Given this list of marker genes NCSTN, RILPL1, OSTM1, PHIP, IL23R, BACH2, AASS, BLNK, H4C3, CTRC, ANLN (NCBI Gene Id 54443), FOXP3, FASLG, PGM2L1, DAAM2, CYP7B1, PTEN, SMARCA2, ATM, CRB2 (crumbs cell polarity complex component 2), EMP2, EPB42, CREBBP, PLG, CRLF1, SKIC3, TREX1, IFT27, HAVCR2, SERPINH1, FRG1, MEIS2, LPL, NPHS2, COL3A1, TCF3, MT-CO3, CORO1A, HR, TNFRSF1B, DNAJB13, DNAH1, LTBP1, TNFSF4, CDC42BPB, TGFB2, ARPC1B, KPTN, DNAJC21, C2orf69, SIAH1, ORC6, SLC35C1, FGFR3, SEMA4D, IDUA, ESAM, C3, PML, SLC12A3, NODAL, WRAP53, SCAPER, RNU12, IL10RA, TBCD, FMR1 (NCBI Gene Id 5421), TBL2 (NCBI Gene Id 27203), MEGF10, BSCL2, HDAC8, TAF6, OCRL, TRAPPC11, PSPH, ANK1, ERCC2, GJB6, GTF2IRD2, NME8, TBC1D8B, NDUFS3, ACTA1, FGF3, CYBB, ARID1A, TNPO3 (NCBI Gene Id 404679), APOE, TLK2, TBC1D2B, AKR1D1, PRG4, ARHGAP24, ASXL1, GJA1, GNPTAB, BBS9 (Bardet-Biedl syndrome 9), CARD14 (caspase recruitment domain family member 14), POU2AF1, TNFRSF9, CD2AP, ABCB1, MT-TF, G6PC1, PIK3CD (NCBI Gene Id 5293), ERCC1, PCCB, MT-ND1, APC2 (APC regulator of WNT signaling pathway 2), SOX11, UFD1, IFT140, NPHP1, UQCRH, GJB2, SREBF1, KDM1A, MEG3, STAT1, SCN9A, ERBB2, ETS1, FOXD3, NLRP1, NHLRC1, AMACR, XPNPEP3, IQSEC2, SH3PXD2B, SLC19A1, POLR3A, PIEZO1, CSPP1 (NCBI Gene Id 79848, centrosome and spindle pole associated protein 1), CACNA1G, RANBP2, HACD1, COL4A5, WDR1, INF2, STUB1, ST14, IL1RN, CYP7A1, MYO1E, LTBP3, EYA4, CST6, COPA, SEMA3C, MTHFD1, USP8, MLX, CBL, LSS, SCNN1A, NCF1, RARA, ZBTB7A, MKS1, TGFBR1, BLOC1S6, DLG1, KCNJ6, IKBKB, RAD21, IGKC (NCBI Gene Id 3514), PLEKHM1, DIP2B, EFEMP2, WDR19, NUP160, CIITA, CTSB, PRMT7, MSN, DNAAF5, NCF2, IL18BP, KIRREL1, TNFRSF1A (TNF receptor superfamily member 1A), TRIM32, PLEC, COG6, RSPH4A, AGR2, CD27 (CD27 molecule), COBLL1, ACTN4, CCDC39, HPS1 (NCBI Gene Id 3257), CIB1, MRTFA, SLC39A7, LEP, TRAPPC2, MMUT, IL6, MT-TS2, ATN1, RFXAP, UBA1, DGKE, NLRP3, EFL1, NEK9, CASR, PRKACA, ACTG2, IGBP1, SLCO2A1, ANO5, STXBP1, CDK10, MAP3K7, BPTF, RECQL, MT-ND6, TLR7, ZEB2, TGDS, STAT6, DNAAF11, CCDC40, SLF2, TGM5, POMP, CPLX1, C1QC, CAV1, PNP, THRB, PAX1, NOTCH2NLC, LRBA, DAW1, SDHA, CD79B, CARMIL2, ZMYM3, PTPRC (protein tyrosine phosphatase receptor type C), FMO3, ELOVL4, SMARCA4, RUNX2 (NCBI Gene Id 860), RAG2, CTLA4, PRKCD, ARHGDIA, GANAB, TNFSF12, IGHG2, ADAR, SRCAP, RBM8A, ANKH, TGFB1, CDKN1B, PIK3R1, IRF5, CEACAM3, KCNN4, KMT2D, STXBP2, TNFRSF11B, KRT10, REV3L, RNF2, COL2A1, DNASE2, JMJD1C, EDARADD, SPTA1, BTD, GTF2IRD1 (NCBI Gene Id 9569), EPHB4, EP300, KMT5B, CLEC7A, CEBPE, KDF1, CFAP74, XIAP, IL2RG, ITK, SPEF2, FBXW7, MME, TOM1, TP53, FECH, DUX4L1, RIT1, RFX7 (NCBI Gene Id 64864), CD28 (NCBI Gene Id 940), IL10RB, PTCD3, ELN, IL12B, GFI1, ARID2, MIA3, MMACHC, AARS1, MALT1, SMG9, JAK2, ZNFX1, CYP4F22, SF3B1, FOXP1, PI4KA, EPCAM, ITGA7, H3-3B, RMRP, DNAH5, HPGD, MAN2B1, RNF113A, ADAMTSL2, MAGI2, NFKB2, HNRNPA2B1, PMM2, DRC1, BCOR, PGM3, TLR8, KANSL1, PLCH1, MBTPS2, NIPBL, OTULIN, CDC73, COX4I2, AXIN1, SLC30A2, TTC12, TNRC6B, DUX4, DOCK8, ERCC3, LAGE3, STX11, KCTD1 (potassium channel tetramerization domain containing 1), IRF1 (NCBI Gene Id 96501), PSTPIP1, XDH, AP1S3, STAT3, SLC2A10, FKBP6, CFTR, LZTFL1, NAE1, MAP2K1, ERCC8, NME5, GCGR, NAA10, STAT5B, PDCD1, SGCG, FLNA, EXTL3, PDGFRL, TNFAIP3, FGF8, NPHS1, CDSN, RNU7-1, ACP5 (NCBI Gene Id 54), PIGH, DLX4, KIF12, DSG1, KANK2, ZNF750, CD81, IL6R, FOXC2, TBL1XR1, STIL, AR, NGF, BCS1L, MEFV, PRSS1, LPIN2, ITGB4, MYH9, ZNF341, AGA, CEACAM6, KRT5, SHOC2, TK2, EPG5, C1S, SFTPB, ALDH18A1, BICC1, CBS, CITED2, CEP19, IFT172, TMC8, ATL3, IDH1, STIM1, DNAAF1, LMNA, CD3D, PERCC1, IGSF3, LTBP4, ANKRD55, SELENON, AK2, DEF6, NAXD, RBCK1, EDAR, BBS12, SLC27A4, MYD88, CR2, ELANE (NCBI Gene Id 6417), LIMK1, CFB, NEK10, KRT14, BAZ1B, AEBP1 (AE binding protein 1), CSTA, CD4, TRPM4, SLC25A12, SMG8, TNFSF15, TBX4, STK36, ARHGEF38, PIGY, GPIHBP1, PTPN6, SCLT1, IGF2R (insulin like growth factor 2 receptor), HBA1, AP3B1, PSMB4, MET, CFAP300, TRIM44, NRTN, GLRB, A2ML1, WDPCP, COMT, KIAA0586, ATP8B1, GAS1, CDCA7, SMARCAL1, RNU4ATAC, SDR9C7, ABCD1, CTC1, GATA1, NUP205, PLCE1, IL12RB1, SMARCB1, CEP290, FGF10, MAB21L1, CERS3, STAT2, SOX18, SLC6A14, GK, KLK11, MTTP, PRORP, PRDM12, FCGR3B, TNIP1, HGD, IL21R, PANK2, EDA, ERCC4, KAT6A, JAGN1, GTF2I, NR1H4, AP1B1, DCLRE1B, RRAS2, RNASEH2B, UBB, IL1R1, NSMCE2, MECP2, METTL27, COL4A4, LMF1, PAPSS2, GJB4, GNB2, GLRA2, DDB2, GATA2, SCNN1B, NUP133, FXN, LONP1, REL, MGP, B4GALT1, SPTBN1, TBK1, NUP93, MNX1, HFE (NCBI Gene Id 3077), TFE3, IFNGR1, PAH, NBN, PRSS2, INSR, FCHO1, C1QB, PTPN22, RSPH3, DNASE1L3, ADA, GIPC1, ACADVL, HLA-DPB1, ALMS1 (NCBI Gene Id 7840), ABCB4, SPTLC2, SLC11A1, POLH, LBR, USB1, CAMK2B, HMOX1, TBX1, TAPBP, BBS4, RFC2, FNIP1, NOS1, RNF125, IL2RB, TPP2, AKT1, COQ8B, GLRA1, KDSR, DISP1, NOD2, GSTM3, MED25, SMC1A, CD151, RFXANK, ERCC6, MTM1, SETD2, IL7R, COL7A1, MED12, CARD10, SH2D1A, DNASE1, BBS5, SMARCD1, PSMB8, AHDC1, RAG1, TG, ABCA12, MAX, IGLL1, MEN1, RETREG1, ARID1B, BTNL2, SFTPC, IFT74, PLXND1, HLA-B, BMP4, MKKS, PHGDH, CCNO, NOTCH2, HYAL1, MBL2, BLK, CFAP410, BTK, RNF168, LRRC8A (NCBI Gene Id 56262), ZFAT, POFUT1, GSN, LMX1B, FGFR1, C1R, AUTS2, DNAAF4 (dynein axonemal assembly factor 4), DNAI2, TPR, MARS2, ABCA3, FCN3, GMPPA, CLDN1, RAB7A, NOP10 (NCBI Gene Id 55505), NPM1, IL17RC, ARSB, APOC2, CASP10, BLM, ALG5, MMP1, NR3C1, MID1, COL11A2, CD19, LPIN1, FGFR2, NSMCE3, TP73, GLIS3, CPA1, FOXH1, RAP1B, MRAP, XPC, SOCS1, PDHA1, DNAH7, SLC25A13 (solute carrier family 25 member 13), FAS, TMCO1, LIG4, LYN, CD247, TBX20, SPAG1, CHD6, TRAF6, HLA-DQB1, TRPC6, MAF, BRD4, JAK1, MPDU1, DDR2 (discoidin domain receptor tyrosine kinase 2), GNAQ, OPLAH, DLL1, COL4A3, TGM1, HSD3B7, VPS33A, MCIDAS, MTAP, TAP2, H4C5, BBS2, LRIF1, CFHR5, ODAD4, KDM6A, CARD8, MST1, GPR101, LYST, PIGG, ALG9, TTC8, ACTC1, CIDEC, GGT1, WDR26, GORAB, CFAP45, ARMC5, DNAH9, DNAH11, DNMT1, SLC9A3, KNSTRN, BBS10, CTNNB1, ROR2, RIC1, POLE, IRAK1, TAF4, CDC45, C4A, B3GALT6, GUCY2C, SLC29A3, PTCH1, SIK3, NFKB1, KIF11, IRF6, GUSB, RPGR, PSENEN, RPL11, BUD23, ERF (ETS2 repressor factor), AAAS (aladin WD repeat nucleoporin), LHCGR, SLC39A4, SIX3, SP110, RREB1, ATRX, POGZ, P4HA2, CLIP2, MYL2, IRF4, CYP11B1, KMT2A, HMGCL, SOX4, PNPLA1 (patatin like phospholipase domain containing 1), TERC, RTL1, NABP1, PLA2G6, IARS2, NUMA1, PSMD12, LIPN, HLA-DPA1, EDN3, GJB3, PURA, UMOD, BCKDK, CLTRN (collectrin, amino acid transport regulator), PSEN1, RHOH, PCYT1A, DCDC2, MT-ND5 (NCBI Gene Id 4540), UNG, TMEM270, NFKBIA, FLG, RTEL1, IL2RA, WT1, SLURP1, BCKDHA, TGFB3, RET, ALOX12B, SMAD3, KIF15, KRT1 (NCBI Gene Id 3848), CAPN5, ADAM17, P4HTM, FOXN1 (NCBI Gene Id 8456), TNFRSF13B, LAMB2, GLI2, UNC13D, ABCB11, FIG4, USP48, IL36RN, CAVIN1, LMNB1, ASAH1, DLK1, HBA2, TKFC, SEC24C, SKIC2, PIK3CA, XPA, PRKAR1A, RELB, CARD11 (NCBI Gene Id 84433), SDCCAG8, ALOXE3, RTTN, SLC6A5 (solute carrier family 6 member 5), SLC25A24, CFAP221, STING1, SRY, CSF2RA, ATP6V1B2, SPTB, ELF4, NDUFA6, IKZF3, TLL1, TARS1, CD40LG, LMBRD1, MMEL1, PKHD1, JAZF1, NCF4, TAOK1, LAMA3, NUP37, ZBTB16 (zinc finger and BTB domain containing 16), ZFX (NCBI Gene Id 7543), GLB1, TKT, MCCC2, NHP2, MT-TH, TMC6 (NCBI Gene Id 117165, transmembrane channel like 6), CDH23, KRT17, LMNB2 (NCBI Gene Id 84823), HEPHL1, GALNS, CIC, PDE11A, TBX2, CFAP52, DNAAF6, SHARPIN, NFE2L2, MIF, TAF1, SHH, KRT74, OFD1, PLCG2, FAM111B, ANKRD11, PIGA, GCLC, TEK, GATA4, IL12A, HYDIN, CLPB, PKD1, SCNN1G, EGFR, SMARCAD1, GRB10, SMC3, GP1BB, FLG2, MAGT1, FLT4, PGM1, DNAL1, IFNG, SNAP29, TP63, DEAF1, WDR35, FANCF, HIRA, IL7, PARN, CYBC1, LAMC2, CRELD1, FLI1, LAMB3, MT-ND4, KIAA0319L, VPS37D, PXK, SH3KBP1, CD3E, SEC23B, TIMM8A, MT-CO1, CD79A, ALDH3A2, MDM4, GBA1, LRRC56, NTRK1, ORAI1, CFI, IFIH1, CLCN7, NF1, ARHGAP29, NADK2, PRKAR1B, ECE1, DNAI1, DKC1 (dyskerin pseudouridine synthase 1), PTPRO, UNC119, TTC7A, MT-CO2, CCBE1, DDB1, RAC1, SDHD, ARVCF, GATA6, SPIB, DNAJB11, TET2, ZMYND10, VPS33B, SIN3A, FBN1, WIPF1, IGHG1 (immunoglobulin heavy constant gamma 1 (G1m marker)), RNASEH2A, LAT, ATL1, SDHC (NCBI Gene Id 6391), ZIC2, NKX2-1, APOL1, C4B, BBIP1, ITCH, MORC2, FAT4, FERMT3, RUNX1, TINF2 (NCBI Gene Id 26277), SLC35A1, PEPD, ANKFY1, BCAP31, SEC61A1, ANGPT2, MAP3K14, ZEB1, ASL, COL17A1, NIPAL4, SNX10, MPEG1, EPM2A, OBSCN, CSF2RB, AGPAT2, MYSM1, SLC25A15, ITGA6, UROS, HBB, DRG1, CLCA4, LSM11, CTSC, MYO1H, ADAT3, TGIF1, RORC, CYBA, PSMG2, ODAD1, LZTR1, BCL10, CLCNKB, SLC4A1, FH, IL17F, JAK3, TBC1D24, FOXJ1, CCDC47 (NCBI Gene Id 57003), CARD9, GDNF, G6PC3 (NCBI Gene Id 92579), MAPK1, BRCA1, GINS1, STAG2, PSMB9, IL37, GNA11 (NCBI Gene Id 93626), FCGR3A, MYT1L, DOCK2, PTPN2, ESR1, RNASEH2C (ribonuclease H2 subunit C), PPARG, CCT5, CFAP418, FLII, HYOU1, PIK3CG, NSUN2, SMO, STAT4, MYCN, FOXC1, PRTN3, CXCR4, SRSF2, HDAC4, DDX41, MT-TW, UBE2L3 (ubiquitin conjugating enzyme E2 L3), TBCK, STX1A, RIN2, CACNA1C, STK4, BAP1, KARS1, IL21, ICOSLG (inducible T cell costimulator ligand), LACC1, INAVA (NCBI Gene Id 91162), SMARCD2, ITGAM, CD3G, GNAS, DPP9, PDGFRA, MAP3K20, DNAJC30, HOXA13, CHD8, HLA-C, COL6A1, NSD1, RSPH1, TONSL, ADAMTS2, DNAAF2, SPI1, TPM3 (NCBI Gene Id 91191), STX16, NLRC4, PAX6, KYNU, APC, AFF4, FLVCR1 (FLVCR choline and heme transporter 1), HLA-DQA1, C1QA, BNC2, H6PD, TERT, CLTCL1, SMARCC2, NXN, MPLKIP, IGHM, SLC7A7 (solute carrier family 7 member 7), SEMA3D, LYZ, TICAM1, HLA-A, LRRC32, WNT4, RIPK1, DOCK11, RNU4-2, POLD3, TCIRG1, DZIP1L, ADA2, CYSLTR2, HLCS, DPF2, WAS, BANK1, TAP1, AIP, IL12A-AS1, KIT, COL4A6, CCR1, F5, ZBTB24, IKZF1, MYH6, TRAF3IP2, DCTN4, AP2S1, UROD, SBDS, CHST14, SAT1, SYK, CBLB, NFS1, SAMD9, IL6ST, ALG12, MVK, LGI3, ODAD2, LETM1, UBAC2, GATA3, BBS1, TGFBR2, ATP7A, CHD7, F13A1, GRHL3, ATOH7, TOP3A, SMCHD1, NKX2-5, BRWD1, CDON, GJC2, RYR1, TRPV6, CASP8, DNMT3B, MCTS1, IKBKG, ZAP70, NRAS, HLA-DRB1, GAPVD1, NUP85, MSMO1, AIRE, COL5A2, LRP12, FCGR2A, UBE2A, SLC26A9, FOCAD, IPO8, PRF1, MYH11, ATP2A2, CLXN, DOLK, CDH1, LDHA, SERPINA1, IRF8, PAX2, XYLT1, SPP1, DYRK1A, DNAAF3, EBP, IVNS1ABP, CAT, TFRC, TRIM8, FZD2, RFX5, TBX19, CAPN3, ARHGEF2, ADAMTS3, SMARCE1, SHPK, CCDC103, FGA, ERBB3, HSPA9, MLXIPL, PPOX, LEMD3, POLA1, MT-TQ, SPINK5, BRAF, ERAP1, ATAD1, IRF2BP2, IDS, GAS2L2, FIP1L1, PKP1, ANAPC1, CARS1 (NCBI Gene Id 833), IRAK4, ZNF699, KRT18, SLC37A4, SASH3, ODAD3, NBEA, TLR4, RAC2, EDNRA, TYMS, DCLRE1C, FERMT1 (FERM domain containing kindlin 1), SETBP1, COL11A1, PSMB10, FCGR2B, COG8, PKD2, NCKAP1L, POLR1A, TCF4, POLG, NUP107 (nucleoporin 107), MT-TL1, TRAC, IL10, MSX1, BBS7, USP26, ATP7B, EIF4H, GNS, LIG1, IVD, ARL6, FBXO11 (NCBI Gene Id 80204, F-box protein 11), PIGN, PRKDC, ATP6V0A1, MNS1, C5, TPM2, RBP4, SPINK1, TNFSF11 (TNF superfamily member 11), GTF2H5, SLC6A19, CTBP1 (C-terminal binding protein 1), SRD5A3, LCK, FBLN5, POGLUT1, ERCC5, NELFA (NCBI Gene Id 7469), IARS1, TFG, TNFRSF13C (TNF receptor superfamily member 13C), EDNRB, PCCA, VIPAS39, GTF2E2, IRF9, RSPH9, BIRC3, SPTLC1, ITGB2, KLRC4, MPV17, COL5A1, F13B, ICOS, ASPRV1 (NCBI Gene Id 151516), MASP2, CALR, LCP2, CRIPTO, GPR35, IRGM, PNPLA2, DSE, SRP19, TNFRSF11A, EN1, SULT2B1, NSD2, GPHN, BCL11B, SAMHD1, IL11RA, NECTIN1, DHCR7, NFIX, GAS8, PLCD1, SUOX, CCDC65, MS4A1, RNF31, PLOD1, CFAP298, NLRP12, SDHB, PAFAH1B1, ARPC5 (actin related protein 2/3 complex subunit 5), RAI1, IL17RA, LAMA2, ECM1 (NCBI Gene Id 1893), ABCC9, here is a description of the gene set: Increased inflammatory response Human Gene Set: HP_INCREASED_INFLAMMATORY_RESPONSE A abnormal increase in the inflammatory response to injury or infection. species: Homo sapiens